Given this list of marker genes GGA3, LDLR, CD81, LRP2, MARCHF2, LRP1, RNF128, here is a description of the gene set: Any process that activates or increases the frequency, rate or extent of protein catabolic process in the vacuole. Human Gene Set: GOBP_POSITIVE_REGULATION_OF_PROTEIN_CATABOLIC_PROCESS_IN_THE_VACUOLE species: Homo sapiens